The following is a description of a gene set: The side (leaflet) of the plasma membrane that faces the lumen. studied in species Homo sapiens Human Gene Set: GOCC_LUMENAL_SIDE_OF_ENDOPLASMIC_RETICULUM_MEMBRANE, and this is the list of marker genes: HLA-DRA (major histocompatibility complex, class II, DR alpha), PKD2, HLA-DRB5 (major histocompatibility complex, class II, DR beta 5), HLA-H, ALG10B (NCBI Gene Id 493903), ALG9, HLA-DPB1, ALG3, CD74, HLA-F, HM13, HLA-DRB3, ALG12, HLA-DPA1, ALG6, HLA-DQA1, TAPBP, HLA-DQB1, HLA-DRB4, SPPL2A, HLA-B, SPPL3, CALR, HLA-DRB1, HLA-A, HLA-C, SPPL2B, CANX, HLA-DQA2, SPPL2C, HLA-E, ALG8, HLA-G, BCAP31, HLA-DQB2